The following is a description of a gene set: Human Gene Set: GOMF_PHOSPHATASE_INHIBITOR_ACTIVITY Binds to and stops, prevents or reduces the activity of a phosphatase. species: Homo sapiens, and this is the list of marker genes: CTNND1, ARPP19, PPP1R1B (protein phosphatase 1 regulatory inhibitor subunit 1B), PABIR3, YWHAE, MGAT5, PPME1, SET, CIP2A, SH3RF2, PPP1R14A, IGFBP2, PPP1R8, PPP1R36, PPP1R2, SIRPA, ELFN1, ANP32E, BOD1, PABIR2, PPP1R35, PHACTR1, YWHAB, HSP90B1, TPRN, PHACTR2, CRY2, PPP1R2C, PTN, PPP1R37, LGALS3, PPP1R11, ELFN2, TESC, PPP1R2B, URI1, PPP4R4, PPP1R1C, ENSA, CABIN1, PPP1R27, PPP1R1A, SAG, STYX, RCAN1, STYXL1, TIPRL, PPP1R26, PPP1R14D, PPP1R9B, PPP1R17, MYOZ1, PPP1R14C, PPP1R2P1, PPP1R14B, LMTK2, PABIR1, PHACTR3, PPP1R10